Given this list of marker genes ADD3, CAPG, SWAP70, DMTN, CKAP2, DIAPH3, CLEC16A, TRIM54, BBOF1, SPEF1, BMERB1, GAS2L2, SPTAN1, TWF1, CLASP2, LMOD3, EPS8, TWF2, GAS2L1, HDAC6, MID1, STMN2, CAPZA2, CAPZB, SPTA1, SPTBN2, PLEKHH2, MID1IP1, VILL, TMOD3, CARMIL1, SPTBN1, AVIL, TMEM39A, SLN, CAMSAP2, PHF23, SCAF8, TMOD2, WASHC2C, ADD2 (adducin 2), CAPZA3, TMOD1 (NCBI Gene Id 7111), MTPN, MAP6D1, TRIOBP, FLII, ASB2, SPTB, CLASP1, ATXN7 (ataxin 7), SCAF4, SVIL, APC2, LIMA1, CARMIL2, SPECC1L, TAOK1, NAV3, CIB1, HDGFL3, RDX, IRAK3, TTBK2, TPX2, MAP1B, CAPZA1, APC, TNF, VIL1, PIK3CA, LMOD1, ADD1, FGF13, UBQLN4, SCIN, RUBCN (rubicon autophagy regulator), LMOD2, ARHGEF2, TMOD4, KATNB1, SPTBN4, CCDC88C, WDR47, GSN, SPTBN5, CFL1 (cofilin 1), CRACD, here is a description of the gene set: species: Homo sapiens Human Gene Set: GOBP_NEGATIVE_REGULATION_OF_PROTEIN_CONTAINING_COMPLEX_DISASSEMBLY Any process that stops, prevents, or reduces the frequency, rate or extent of protein complex disassembly, the disaggregation of a protein complex into its constituent components.